Given this list of marker genes B3GALNT2, B3GALT5, GXYLT2, ST6GALNAC2, POGLUT2, POFUT1 (NCBI Gene Id 23509), GALNT2, GALNT11, POFUT2, PLOD1, C1GALT1, XXYLT1, GCNT1, FUT4, POGLUT1, VEGFB, TRAK2, ST3GAL1, GALNT1 (NCBI Gene Id 2589), B3GNT6, GXYLT1, RXYLT1, B3GNT3, B3GNT4, C1GALT1C1, B4GALT5, SLC35C2, CHST4, CRPPA, FKRP, MGAT5B, B3GALT1, FUT6, B4GAT1, GALNT7, B3GNT5, ST3GAL4, PLOD3, GALNT13, POMGNT1, FUT9, TMTC4, OGT, FUT3, GALNT3, TMTC1, OGA, B3GLCT, TET1, GALNT6, ST6GAL1, B3GALT4, TMTC3, TET3, B3GNT2, ST6GALNAC4, GALNT12, FKTN, LARGE1, B3GNT8, B3GALT2 (beta-1,3-galactosyltransferase 2, NCBI Gene Id 90195), PGM3, GALNT10, B3GNT7, DPM1, GALNT15, ST8SIA6, POGLUT3, EOGT, TMEM260, POMT1, B3GALT9, B3GALNT1, GALNT4, GALNT16, GALNTL6, GALNT17, B3GALT6, TET2, POMK (protein O-mannose kinase), FUT5, GCNT3, TRAK1, TMTC2, DPM3, GALNT18, FUT11, A4GNT, COLGALT1, POMT2, B3GNT9, GALNT5, ST3GAL3, LARGE2, FUT10, GALNT8, POMGNT2, GALNT9, GCNT4, GALNT14, PLOD2, ST3GAL2, here is a description of the gene set: Human Gene Set: GOBP_PROTEIN_O_LINKED_GLYCOSYLATION species: Homo sapiens A protein glycosylation process in which a carbohydrate or carbohydrate derivative unit is added to a protein via the hydroxyl group of peptidyl-serine, peptidyl-threonine, peptidyl-hydroxylysine, or peptidyl-hydroxyproline, or via the phenol group of peptidyl-tyrosine, forming an O-glycan.